Given this list of marker genes MICAL2, HTN3, LBP (lipopolysaccharide binding protein), AZU1, S100A12, NQO1, EPHX1, ADH1A, MGAM, UGT2B15, DEFA5, EPHX2, MGLL, VNN2, RNASE3, SI, PGLYRP1, ALDH1A3, ADH4, VNN1, CAMP, DEFB4A, LYZ, DEFB1, AKR1C1, LALBA, BPI, ALDH3B1, BTD, DEFA4, SULT1C2, GNLY (NCBI Gene Id 7843), KMO, FMO4, ALDH3B2 (aldehyde dehydrogenase 3 family member B2), PRG2, CD14, here is a description of the gene set: studied in species Homo sapiens Xenobiotic metabolism. Human Gene Set: MODULE_247